Given this list of marker genes Slc2a13, Aph1c, Abca2, Clu, Bin1, Ncstn, Adam10, Rtn3, Picalm, Lrrtm3, Epha4, Gsap, Hap1, Bace1, Tmed10, Tnf, Abcg1, Casp3, Gsk3a, Sp1, Spon1, Aph1b, Ntrk2, Ifng, Psen2, Psen1, Pin1rt1, Gga3, Csnk1e, Apoe, Ifngr1 (interferon gamma receptor 1), Aph1a, Rock1, Rtn1 (NCBI Gene Id 97843), Tmed10-ps, Chrna7, Igf1, Dyrk1a, Pin1, Rtn2, Abca7, Prnp, Rock2, Rps23rg1, Efna1, Rtn4, Sorl1, Rela, Psenen, here is a description of the gene set: The generation of amyloid-beta by cleavage of the amyloid precursor protein (APP). species: Mus musculus Mouse Gene Set: GOBP_AMYLOID_BETA_FORMATION